The following is a description of a gene set: studied in species Homo sapiens Human Gene Set: HP_THICKENED_HELICES Increased thickness of the helix of the ear. Thickened helices, and this is the list of marker genes: DYRK1A, TCF4, GDF11, NRAS, PGAP2, RIT1, DIS3L2, LZTR1, PIGO, MAP2K1, PIGS, RASA2, PIGW, RB1, TAF1, ADAMTSL2, RAF1, CDH2, KRAS, RRAS2, PBX1, BMP2, MAP2K2, SOS2, RRAS (RAS related), SPRED2, DDX3X, PPP1CB, SOS1, SPOP, PIGY, PIGV, FGFR2, CBL, H4C5, SIN3A, MRAS, PGAP3, AFF4, BRAF, PIGL, FBN1, EDEM3, ZFX, SMS, XYLT2, SUPT16H, PTPN11